The following is a description of a gene set: from publication Cao J, O'Day DR, Pliner HA, Kingsley PD, Deng M, Daza RM, Zager MA, Aldinger KA, Blecher-Gonen R, Zhang F, Spielmann M, Palis J, Doherty D, Steemers FJ, Glass IA, Trapnell C, Shendure J (PMID 33184181) The gene expression program underlying the specification of human cell types is of fundamental interest. The study authors generated human cell atlases of gene expression and chromatin accessibility in fetal tissues. For gene expression, the study authors applied three-level combinatorial indexing to >110 samples representing 15 organs, ultimately profiling ~4 million single cells. The study authors leveraged the literature and other atlases to identify and annotate hundreds of cell types and subtypes, both within and across tissues. Our analyses focused on organ-specific specializations of broadly distributed cell types (such as blood, endothelial, and epithelial), sites of fetal erythropoiesis (which notably included the adrenal gland), and integration with mouse developmental atlases (such as conserved specification of blood cells). These data represent a rich resource for the exploration of in vivo human gene expression in diverse tissues and cell types. Human Gene Set: DESCARTES_FETAL_LUNG_VASCULAR_ENDOTHELIAL_CELLS Marker genes curated from the annotated cluster as represented in the Descartes Human Gene Expression During Development database. studied in species Homo sapiens, and this is the list of marker genes: ENSG00000233251, EDN1, APLN, NPR3, SOX7, BTNL9, PRX, ACE, SHROOM1, IL33, ENSG00000272789, LINC02751, TMEM100, VWF, ESM1, S100A3, TCIM, COLEC10, JAM2, NOSTRIN, ULBP1, RNU6-570P, BBOX1-AS1, ANO2, MADCAM1, PRND, TCF15, MUC19, DPEP1, FCN3, ULBP2, RNGTTP1, NOTCH4 (notch receptor 4), RGCC, MMRN2, RXFP1, NEURL1B, PLK2, SLC22A10, SELE, RN7SL517P, ENSG00000253348 (NCBI Gene Id 107986474), ADORA2A (NCBI Gene Id 135), LHX6, RN7SL69P, APLNR, CD300LG, FOXS1, CD93, KIT, ENSG00000257002, CLEC3B, CLEC1A, MYOC, SLC22A25